Given this list of marker genes ALPL, TMEM38B, WNT11, RXRB, SLC24A3, AXIN2, CCL3, GPC3, ZMPSTE24, PTHLH, FGF23, ADRB2, PTK2B, SLC8A1, COL6A1, STATH, BGLAP, BMP7, ERCC2, ROGDI, TXLNG, AHSG, ATP2B1, SMPD3, ASPN, CCDC154, FBXL15, KL (klotho), BMPR1A, ANO6 (anoctamin 6), TMEM119, SRGN (NCBI Gene Id 5552), ACVR2A, OSR2, PHEX, ZBTB40, FAM20C, ADGRG6, ALOX5, ALOX15, GREM1, IGF1, PTN, FGFR2, TUFT1, MATN1, RFLNB, COMP, IFITM5, VDR, ATF4, MEF2C (myocyte enhancer factor 2C), RUNX2, ECM1, S1PR1, FGR, ACVR2B, GPM6B, WNT4, BMP4, OSR1, MMP13, RXRA, MIR208A, RFLNA, LGR4, ISG15, ACTN3, SBDS, NBR1, SNX10, BCOR, LTBP3, BMPR2, SMAD3, GATA1, NELL1, IBSP, BMP2, P2RX7, SBNO2, BMPR1B, TWIST1, FZD9, CYP27B1, BMP6, LEP, EIF2AK3, HIF1A, ENPP1, LTF, SUV39H1, MINPP1, PRICKLE1, HERC1, ADGRV1, TENT5A, IFT80, ACVR1, BMP2K, TFAP2A, CLEC3B, FBN2, ATRAID, RSPO2, DDR2, MGP, SOX9, KLF10, WNT10B, LOX, PTH1R, SGMS2, ANKH, FOSL2, PTH, CER1, PHOSPHO1, COL1A2, PKDCC, FKRP, FGFR3, NOTUM, CCR1, TRPM4, SLC20A2, CCN1, here is a description of the gene set: Human Gene Set: GOBP_BONE_MINERALIZATION The deposition of hydroxyapatite, a form of calcium phosphate with the formula Ca10(PO4)6(OH)2, in bone tissue. studied in species Homo sapiens